The following is a description of a gene set: The activation signaling of transcription factor nuclear factor-kB (NF-kB) plays central role for immune system. One of key kinase mediating this pathway is TAK1 in adaptive and innate immunity. However, role of TAK1 in B cell receptor signaling is still unclear. To know effects of TAK1-deletion on the gene expression induced by anti-IgM, we performed the time course analysis in comparison of wild type with TAK1-deleted splenic B cells. species: Homo sapiens from publication Shinohara H, Behar M, Inoue K, Hiroshima M, Yasuda T, Nagashima T, Kimura S, Sanjo H, Maeda S, Yumoto N, Ki S, Akira S, Sako Y, Hoffmann A, Kurosaki T, Okada-Hatakeyama M (PMID 24833394) Human Gene Set: GSE41176_UNSTIM_VS_ANTI_IGM_STIM_TAK1_KO_BCELL_24H_DN Genes down-regulated in B lymphocytes with MAP3K7 knockout: untreated versus anti IgM for 24h., and this is the list of marker genes: SEMA4A, SLC11A2, FBXW11, LYRM1, ANKRD6, MT2A, ZNF667, TUB, WDFY3, FCER1G, SLC7A7, ADA, LAPTM4B, MARCO (macrophage receptor with collagenous structure), NFKBIA, MT1HL1, S100A9, SOCS2, PLAGL2, SLC6A9, PKD2, DEXI, PRELID3B, CD47 (NCBI Gene Id 961), CYP11A1, CCL13, GNA12, PRR3, LTBP2, ZBTB6, HPSE, MXRA7, HMGA2, CHI3L1, LILRA3, ATP2C1, PTX3, METTL9, MT1M, CPD, KIR2DS2, MIER2, IDO1, LIMA1, NOL10, TRPM2, MBOAT7, SLC39A8, BTG3, CHIA, RPH3A, MAOA, STEAP1, TNIK, PPP1R17, RGS3, NFAT5, CSF2RB, H1-0, MYO10, SIX2, RBM12 (RNA binding motif protein 12), TBC1D30, UBE2NL, TBC1D13 (TBC1 domain family member 13), MOS, CUX1, DSE, SMPDL3A, LIMK2 (LIM domain kinase 2), TSPAN13, ADAM10, DAZAP1, MT1H, ADTRP, SEMA3E, N6AMT1, MT1F, MXD1, NCF1C, VCAN, SMAD5-AS1, SYT17, CD82, DRD5, FJX1, GTDC1, MT1G, KPLCE (NCBI Gene Id 553168), SH2D2A, LAMP3, ORM1, ST3GAL1, ACO1, CDK14, CLEC4E, SLC25A13, UCP2, ADM, KCNJ15 (NCBI Gene Id 3772), SLC13A1, ZFTA, PROCR, NDST2, S100A12, DDIT4, DUSP14, PPM1H, CCL20, HCK, CSRP1, CYP2A7P1, BASP1, RIOX2, STXBP2, SRPK1, IFNG, IFNGR2, LAIR1, GNG10, ADGRE1, NXT1, MET, GLUL, GNA15, ZBTB10, FZD5, JADE3, SMG7-AS1, PRR16, CHMP2B, TNFAIP3, AFAP1, PSTPIP2, PID1, PFN2, ADGRG3, SAMSN1, PLP1, PLP2, ADAM8, MT1X, MPHOSPH6, CTSB, C2CD3, RRS1, CDY1, S100A8, EEF1AKMT3 (EEF1A lysine methyltransferase 3), FOXI1, CH25H, LAPTM5, SASH1, S100B, TPST1, RETN, CEACAM3, PDPN, MYC, MARCKSL1, SLC24A3, CDCA4, SLC16A10, PLSCR1, PILRA, PI3, TRIM36, WDR3, TRPC5, PTGES, FPR1, NETO2, STEAP3, PNMA1, ARMT1, BRIX1, CALCRL, LAT2, DDX21, CKAP4, ETV5, EPB41L3, TSPAN7, RFPL1, CASP5, P4HA1, CFP, AZIN1, MAFG, ZPBP, TNS3, TLL2, ATF6, VOPP1, P2RY6, MT1E, CCL19, NT5DC2, MCTP2